Given this list of marker genes FANCE, NCOA1, TOP2B, ZNF878, AGPS, XRCC5, VAV2, MED11 (NCBI Gene Id 400569), AMDHD2, MUTYH, PARS2, VPS16, SLC35B3, ITGAV, EXOSC5 (exosome component 5), RCCD1, FAM117B, MAP3K5, SF1, MMD, NUP210 (nucleoporin 210), RRAS, WWC2, NDST2, HYCC1, GMFG, C12orf57, TUSC3, CYP4V2, VEZF1, PDPR, PHC3, ENTPD5, MBOAT7, SNX5, PADI2, TOR4A, TRAP1, ARHGAP24, CTDSP1, GPR137B, SCAI, RABEP1, MTG2, C19orf48P, CEP250, GNGT2, NEK9, ITPR3, TMEM209, TRIM65, CYBC1, PPP1R3F, DNAJB5, PGLS, ZNF398, NFRKB, SYNE1, SLC2A4RG, DGCR2 (NCBI Gene Id 9993), RDH12, PPM1K, TEF, CTSC, ORMDL1, APOBEC3B, MACIR, LRRC23, LAMB3, SS18, GNB1, EIF3F, MARVELD2, RASSF5, TNK2, NCOR2, CORO1B, ATP2A3, MPHOSPH9, VPS33A, ZMIZ1, MCMBP, DAZAP2, NEDD4L, MTG1, ZC3H7B, CRYBG3, TESK1, HNRNPM, BCL7A, DUS2, MDC1, LIPT1, USB1, MYCBP2, ALDH6A1, MECP2, MIDN, CFAP96, PEX10, SMC6, FIBP, BLTP1, SNAI3, ARID1A, TRMU, CD52, STRN4, DPYSL2, IFT74, BRAT1, C16orf90, CD2AP (NCBI Gene Id 25916), SIAH1, INTS7, ST13, ZC3H12A, EXOC6, FKBP3, GPATCH4, CHD6, VPREB3 (NCBI Gene Id 29802), GOLM1, CDK10, SNAPC1, SIDT1, KANSL2, RPS7 (ribosomal protein S7), STX2, TMEM181, SMURF1, CLIP1, CAST, OBI1, TPD52, RGS18, TENT4B, SLC37A4, EID1, MAX, RCN2, MIER2, KANSL1, PTGR3, ZNF638, SLK, GALNT4, DFFA, SUN2, METTL3 (methyltransferase 3, N6-adenosine-methyltransferase complex catalytic subunit), CRTC2, SPTBN1, TMC6, TMEM86A, SLC6A6, RBM33, DIRAS2, LRRC75A, WIPF1, KHDRBS1, PCM1, AIP, KCTD14, AP1G2, TDO2, EMC4, DEPDC5, CHMP1B, MSN, USP21, PIGR, OTULIN, SPNS1, S1PR1, LIPT2, B3GAT3, PPM1L, HLA-DRA, SETD1A, ARFRP1, LIAT1, DVL2, ASAP1, MTRF1L, ZDHHC23, MEST, PLCB3, TOR1AIP1, TUT1, FUCA1, RGL2, ARGLU1 (NCBI Gene Id 55082), ARHGAP35, SMAD2, NFATC2IP, TRMT6, PHF2, IRGM, PSKH1, ZNF689, here is a description of the gene set: Genes down-regulated in macrophages: wildtype versus SOCS3. from publication Lang R, Pauleau AL, Parganas E, Takahashi Y, Mages J, Ihle JN, Rutschman R, Murray PJ (PMID 12754506) Effects of SOCS3 on the transcriptional response of bone marrow-derived macrophages to IL-6. Fetal liver cells from SOCS3+/+ or SOCS3-/- embryos were used to reconstitute recipient mice. Donor derived bone marrow from these mice was differentiated to macrophages. Macrophages were either unstimulated, or stimulated for 100 or 400 minutes with 10 ng/ml IL-6. species: Homo sapiens Human Gene Set: GSE411_WT_VS_SOCS3_KO_MACROPHAGE_DN